The following is a description of a gene set: Human Gene Set: GOBP_REGULATION_OF_SISTER_CHROMATID_SEGREGATION Any process that modulates the frequency, rate or extent of sister chromatid segregation. studied in species Homo sapiens, and this is the list of marker genes: CENPF, CDC6, ACTB, ANAPC4, ANAPC1, ESPL1, KNL1, XRCC3, NSMCE2, SKA1, TRIP13, SMARCE1, INCENP, ANAPC15, BCL7A, RB1, PBRM1, SIRT1, ARID2, MAD2L1, DLGAP5, ZW10, RAD21, KLHL22, SKA3 (NCBI Gene Id 221150), DUSP1, ZWILCH, TACC3, MAD2L1BP, CDC27, PLK1, ANAPC5, BECN1, APC, NDC80, SMARCD1, BCL7C, FBXO5, SMARCA2 (NCBI Gene Id 95083), HECW2, ANAPC11, CDC16, TPR, MAD1L1, BIRC5, RMI2, NEK6, CDC23, NUMA1, DPF1, CDC20, KNTC1, TTK, LCMT1, CDCA8, NUF2, IK, DPF2, ANAPC2, RIOK2 (RIO kinase 2), CHFR, ATM, BRD7, PRP4K, KAT2B, DPF3, SMARCC1, BUB1B, CDK1, TEX14, UBE2C, MOS, BUB1, MAPK15, PSMG2, HNRNPU, ARID1A, SMARCD3, SMARCA4, BUB3, CCNB1, SMARCC2, SPDL1, SMARCB1, ANAPC7, CDK5RAP2, MAD2L2, PHF10 (NCBI Gene Id 55274), ZNF207, ACTL6B, MAP3K20 (NCBI Gene Id 51784), ZWINT, CENPE, USP44, GEN1, SPC25, DYNC1LI1, SPC24, KAT5 (NCBI Gene Id 10524), ARID1B, HASPIN, CUL3, AURKB, SMARCD2, ACTL6A, BCL7B, PRAP1